Given this list of marker genes Tbc1d30, Mapre2, Spink5, Sacm1l, Car8, Fam120a, Steap2, H2-Eb2 (NCBI Gene Id 631971), Prokr2, Tmem45a, Zfp148, Ifi44, Mfsd6, Wnk3, Mier1, Far1, Grhl3, Pou3f2, Slc39a8, Mbnl1, Smarca1, Npy1r, AI593442 (NCBI Gene Id 330941, expressed sequence AI593442), Cntn4, Prrg1, Fbxo43, App, Abi1, Ccdc169 (NCBI Gene Id 320604), Mmgt1, Zfp800, Grb10, Tpgs2, Magi1, Sp3, Serp1 (NCBI Gene Id 28146), Slc5a7 (NCBI Gene Id 63993), Srpk2, Cpeb2, Sri, Elmod1, Zfp711, Septin10, Gabrb3, Znhit6, Uts2b, Map3k8, Eif4e, Dmc1, Ttc28, Elf2 (NCBI Gene Id 99951), Kdm4c, Galnt7, Hook3, Iglon5, Apobec3, Agfg1, Stk4, Nalf1 (NALCN channel auxiliary factor 1), Srsf7, Sec62, Arglu1, Agap1, Azi2, Pank3, Mfap3l, Nrg3, Slc28a3, Zfp819, Rad51d, Kpna3, Ulk1, Zdhhc15, Xirp2, Trmt2a, Dicer1, Camk2d, Thsd7a, Rbmxl2, Pparg, Dr1, Elavl4 (NCBI Gene Id 15572), Gucy2f, Frk, Zfp760, Mbtps1, Atp11a, Clasp2, Erg, Adamtsl3, Frs2, Asxl3, Ndfip2, Kcnb2, Brd10, Cltc, Ildr2, Lipg, Atg3, Pou3f3, Med13, Crppa, Wdr76, Tcim, Pfn2, Ireb2, Ro60, Ric8b, Cxadr, Baz2a, Onecut2, Zdhhc21, Cox15, Ednrb, Sirt1, Smc2 (NCBI Gene Id 67947), Mapk1, Ubxn4, Tm6sf1, Slc35f4, Otx2, Cd8a, Chd9, Trim8, Csf3, Ipo5, Rgs4, Hif1a, Caprin1, Kctd6, Smarca5, Pkn2, Ubqln1, Tnfsf15, Gpr158, Cntn3, Fam120c, Mindy2, Irgm2, Naalad2, Jph3, Hipk3, Fkrp, Glrb, Trp53inp1, Guf1, Agbl3, Syde2, Fam184b, Dact1, Snap25, Glcci1, Fzd10, Rock1, Chrdl1, Dhx57, Wsb1, Nrip1, Stx12, Rnf6, Phactr2, Cdk17, Klhl15, Rab21, Cpeb4, Scn4b, Fbrsl1, Pclo, Cep170, Speer4b, Cdk19, Gabra6, Rusf1, Ube2a (NCBI Gene Id 56394), Slc25a53, Cadm2, Sox11 (SRY (sex determining region Y)-box 11), Rag1, Rhobtb3, Cfap418, Tdrd3, Sowahc, Slc25a32, Tvp23a, Ajap1, Smim13, here is a description of the gene set: Mouse Gene Set: MIR_669H_3P Genes predicted to be targets of miRBase v22 microRNA mmu_miR_669h_3p in miRDB v6.0 with MirTarget v4 prediction scores > 80 (high confidence targets). species: Mus musculus from publication Chen Y, Wang X (PMID 31504780)